The following is a description of a gene set: species: Homo sapiens Handgrip myotonia Human Gene Set: HP_HANDGRIP_MYOTONIA Difficulty releasing one's grip associated with prolonged first handgrip relaxation times., and this is the list of marker genes: CLCN1, PURA, CNBP, HINT1, SCN4A, ACTA1